Given this list of marker genes ANO1, KCNN1, TRPM5, PKD2L1, CATSPER1, CATSPER4, KCNMB2, TMEM63C, TMEM63A (NCBI Gene Id 9725), KCNMB3, KCNU1, CCT8L2, KCNMB1, KCNN2 (potassium calcium-activated channel subfamily N member 2), KCNN4, PKD1L3, KCNK18, ASIC2, KCNT1, TMEM63B, ANO10, CATSPER2, KCNN3, TRPC3, ASIC1, CALHM1, TRPM4, KCNT2, KCNMA1, KCNMB4, ANO6, here is a description of the gene set: Human Gene Set: GOMF_MONOATOMIC_ION_GATED_CHANNEL_ACTIVITY Enables the transmembrane transfer of a solute by a channel that opens in response to a specific ion stimulus. studied in species Homo sapiens